Given this list of marker genes VIPAS39, AKR1D1, HSD3B7, VPS33B, AMACR, here is a description of the gene set: Giant cell hepatitis studied in species Homo sapiens Human Gene Set: HP_GIANT_CELL_HEPATITIS Chronic hepatitis characterized by parenchymal inflammation with formation of large multinucleated hepatocytes in response to a variety of insults to the liver.